Given this list of marker genes Ntrk2, Spon1, Rtn4, Rtn2, Gsk3a (glycogen synthase kinase 3 alpha), Tnf, Sorl1 (NCBI Gene Id 72910), Abca2, Efna1, Rtn3, Csnk1e, Sp1, Abca7 (NCBI Gene Id 27403), Gsap, Casp3, Epha4, Clu, Igf1, Prnp, Rela, Abcg1, Picalm, Rock2, Lrrtm3, Hap1 (huntingtin-associated protein 1), Bin1, Slc2a13, Rps23rg1, Ifng, Rtn1, Ifngr1, Pin1, Chrna7, Tmed10-ps, Apoe, Rock1, Pin1rt1, Gga3, Tmed10, here is a description of the gene set: Mouse Gene Set: GOBP_REGULATION_OF_AMYLOID_BETA_FORMATION species: Mus musculus Any process that modulates the frequency, rate or extent of amyloid-beta formation.